Given this list of marker genes Ptch1, Gli1, Tyms, Csnk2a1, Pcna, Egfr, Tgfb1, Hmox1, Il10, Vtn, Cpb2, Gfer, Cpt1a, Ccnd1, Pnpt1, Hfe, Cebpb, Sulf2, Reg1, Ggt1, Tnf, Cldn1, Slc7a5, Ezh2, Gli3, Itpr1, Rpl10, Il6, Ptpn3, Ucp2, Aurka, Serpina10, Ezh1, Rgn, Ihh, here is a description of the gene set: studied in species Mus musculus Mouse Gene Set: GOBP_LIVER_REGENERATION The regrowth of lost or destroyed liver.